Given this list of marker genes TYMP, GHRL, GHSR, NPR2, NMU, NPPC, here is a description of the gene set: The spontaneous peristaltic movements of the stomach that aid in digestion, moving food through the stomach and out through the pyloric sphincter into the duodenum. Human Gene Set: GOBP_GASTRIC_MOTILITY species: Homo sapiens